Given this list of marker genes PLEKHA1, MPP7, GOT1L1, EEF1G, RNASE13, SNORD37, IFI16, SLC12A2, METTL27, PATJ, POU2AF1, RBBP6, LTB, CHD3, KRBA1, GRWD1, SLC35A1, RNF144A, RALGPS2, OTOA, VAV3, CLIC3, NEFH, ATXN7L1, REL, CFP (NCBI Gene Id 5200), TSHB, SH3BP5, GPR183, EYA2, SRY, NCF1, XCL1, NSG2, SRSF6, TREML2, CD9, RDH16, RPL36A, EXT1, IL7R, TNFSF8 (TNF superfamily member 8), GPATCH4, ABCG4, WDSUB1, BANP, PQBP1 (NCBI Gene Id 5974), POLR3E, MYB, DAPL1, INSR, PRSS43P, CARMIL2, TACC2 (transforming acidic coiled-coil containing protein 2), VWA3B, ZDHHC23, LITAF, PTPN13, CD22, C1QA, SH2B3 (SH2B adaptor protein 3), RTP4, MIP, IL6ST, CAPN15, AFF3, FOXP1, AIM2, RNF213, PPRC1, TRIM34, MIF, IL6R, SMAD1, ANKRD61, FANCL, FCHSD2, RPL18, KCNJ5, GAR1, RBM19, LAPTM4B, ALPL, SLC43A1, EGR2, PRMT3, B3GNT3, PDK1, CRTAM, TET3, SSBP2, ABCD2, PECAM1, BACH2, CXCR5, RAI1, NFKBIA, RGS10, RAPGEF4, CBX7, MFSD13A, ACTN1, ZNRF1, PZP, SELL, TSPAN3, ANKRD6, SIK1, SYCE1, CD2AP, EVL, TCF7, DGKA, SMAD5, INPP4B, CCR7, NET1, SPINT2, VWA5A, QTRT2, PLD4, TNF, SPACA6, MOV10L1, RAB3IP, CD5, IZUMO1R, PLXND1, TWSG1, TMEM42, UFSP1 (UFM1 specific peptidase 1), SGK3, CNR2, STRBP, PRDM11, MDN1, APOC4, NPM1, BTLA, POU6F1, RAVER2, TNFRSF25, PNPO, SMAGP, SLAMF6 (NCBI Gene Id 114836), P2RX7, MYC, TOX, GYS1, TSGA10IP, here is a description of the gene set: Human Gene Set: GSE40274_CTRL_VS_EOS_TRANSDUCED_ACTIVATED_CD4_TCELL_DN The transcription factor FoxP3 partakes dominantly in the specification and function of FoxP3+ CD4+ T regulatory cells (Tregs), but is neither strictly necessary nor sufficient to determine the characteristic Treg transcriptional signature. Computational network inference and experimental testing assessed the contribution of several other transcription factors (TFs). Enforced expression of Helios or Xbp1 elicited specific signatures, but Eos, Irf4, Satb1, Lef1 and Gata1 elicited exactly the same outcome, synergizing with FoxP3 to activate most of the Treg signature, including key TFs, and enhancing FoxP3 occupancy at its genomic targets. Conversely, the Treg signature was robust to inactivation of any single cofactor. A redundant genetic switch thus locks-in the Treg phenotype, a model which accounts for several aspects of Treg physiology, differentiation and stability. Genes down-regulated in CD4 T conv: control versus over-expression of IKZF4. from publication Fu W, Ergun A, Lu T, Hill JA, Haxhinasto S, Fassett MS, Gazit R, Adoro S, Glimcher L, Chan S, Kastner P, Rossi D, Collins JJ, Mathis D, Benoist C (PMID 22961053) species: Homo sapiens